The following is a description of a gene set: from publication Chen Y, Wang X (PMID 31504780) species: Homo sapiens Human Gene Set: MIR1197 Genes predicted to be targets of miRBase v22 microRNA hsa-miR-1197 in miRDB v6.0 with MirTarget v4 prediction scores > 80 (high confidence targets)., and this is the list of marker genes: ZNF501, SCG2, STMN4, GABRG2, TPTE2, DENND6A, REPS2, ATP11C, GGA3, LRP4, ADD3, GNAL, MADD, HAO1, RBFOX2, CHST11, THRB, ZNF85, MEIS2, MAT2A, AK2, SLCO6A1, KDM7A, CADPS, PRELP, QPCT, ITGB1BP1, ARGLU1, GMIP, CEP170, RB1, RPAP1, SESN3, NMNAT2, DGKD, SPOCK2, SLC4A4, FHL1, RAB7B (NCBI Gene Id 84855), USP35, COL2A1, CD300LF, OPCML, DYNC1I1, GFM2, CREM, MED13L, NDST3, MCM6, AUTS2, SOCS5, MLLT3, TRAK2, PSMA1, EIF5, GCLM, CA10, PTPN5, PAXBP1, HADHB, USP49, TRIM38, BBS4, CBL, PDYN, EPHA7, STAG1, CLSTN1, ASAH2B, SMIM13, UBE2J1, KIF18B, FEZ2, CTDSPL2, RFLNA, MAP3K9, SLC35D3, DNAJC27 (NCBI Gene Id 51277), KRAS, PURA, LONRF2, PIANP, HS2ST1, MAP3K1 (mitogen-activated protein kinase kinase kinase 1), NEO1, RAB11FIP4, CCDC28A-AS1, EMC7, STAG3, ATAD2, TENM1